The following is a description of a gene set: species: Homo sapiens Human Gene Set: GOBP_CELLULAR_RESPONSE_TO_STEROL_DEPLETION Any process that results in a change in state or activity of a cell (in terms of movement, secretion, enzyme production, gene expression, etc.) as a result of a stimulus indicating deprivation of sterols. Sterols are a group of steroids characterized by the presence of one or more hydroxyl groups and a hydrocarbon side-chain in the molecule., and this is the list of marker genes: ERLIN2, MIR96, ERLIN1, SPRING1, INSIG1, AMFR, PAQR3, ARHGEF10L, NPC1L1, EIF2A, INSIG2, FBXW7, SCAP, SREBF1, TMED2, ZBTB7B, SREBF2